Given this list of marker genes ANAPC1, PSMC6, PSMB2, PSMA5, ANAPC16 (NCBI Gene Id 119504), PSMB1, ANAPC15, PSMD11 (proteasome 26S subunit, non-ATPase 11), CCNA2, PSMB3, PSMD13, PSMC5, ANAPC10, PSMD6, PSMC3, FZR1, UBA52, SEM1, PSMA3, PSMC1, ANAPC2, ANAPC11, CCNA1, PSMB7, CDC27 (NCBI Gene Id 996), CDC16, ANAPC5, PSMC4, UBE2D1, UBE2S, PSMB5, UBC, PSMA4, PSMD2, PSMD7, PSMD3, ANAPC4, PSMA2, UBE2C, UBB, PSMB4, CDC26, PSMB6, PSMA6, CCNE2, PSMA1, PSMD14, CDC6, ANAPC7, CDK2, ADRM1, PSMC2, CCNE1, RPS27A (ribosomal protein S27a), PSMD1 (NCBI Gene Id 5707), PSMD8, CDC23, PSMA7, PSMD12, UBE2E1, here is a description of the gene set: CDK-mediated phosphorylation and removal of Cdc6 studied in species Homo sapiens Human Gene Set: REACTOME_CDK_MEDIATED_PHOSPHORYLATION_AND_REMOVAL_OF_CDC6